Given this list of marker genes SGMS2, KDSR, CERS2, ASAH1, E2F1, CDK2, GLB1, S1PR2, MTOR, CERS4, SPHK1, S1PR5, TERT, SPTLC1, PLCB1, RPP38, SMPD3, PRKCA, CDKN1A (NCBI Gene Id 1026), S1PR1, RB1, CDK4, GBA1, SGPP1, PRKCB, MAPK1, DEGS1, UGCG, here is a description of the gene set: Sphingolipid metabolism in senescence species: Homo sapiens Human Gene Set: WP_SPHINGOLIPID_METABOLISM_IN_SENESCENCE